Given this list of marker genes C4BPB, C4A, CFI, C4B (NCBI Gene Id 721), C1QC, C8G, C1RL, IGHA2, C8B (complement C8 beta chain), C7, C6, C9, IGHE, C1S, IGHA1, SERPING1, MASP2, IGHG1, C3, CD46, IGHG3, CR1, IGHG2, CR1L, C4BPA, TREM2, C1QBP, C5 (complement C5), C1R, C1QB, C8A, CR2, C1QA, CD55, C2, IGHG4, SUSD4, CLU, MBL2, IGHD, here is a description of the gene set: Human Gene Set: GOBP_COMPLEMENT_ACTIVATION_CLASSICAL_PATHWAY Any process involved in the activation of any of the steps of the classical pathway of the complement cascade which allows for the direct killing of microbes, the disposal of immune complexes, and the regulation of other immune processes. studied in species Homo sapiens